Given this list of marker genes NPPA, CHGA, ADRA1A, UCN, KCNQ1, RGS2, MIR1-1, ACE2, HSP90AA1, here is a description of the gene set: Any process that increases the frequency, rate or extent of cardiac muscle contraction. species: Homo sapiens Human Gene Set: GOBP_POSITIVE_REGULATION_OF_CARDIAC_MUSCLE_CONTRACTION